Given this list of marker genes DFFB, FASLG, FAS, ACTA1, MAPK8, CASP10, MAP3K1, APAF1, FADD, HSPB1, MAPKAPK3, CYCS, DAXX, TNF, SMIM40, CASP7, CFLAR, CASP9, PAK1, MAP3K7, PAK2, MIR34C, CASP6, CASP3, ARHGDIB, FAF1, RB1, SPTAN1, PARP1, LMNA, LMNB2, MAPKAPK2, PRKDC, ACTB, ACTG1, LMNB1, IL1A, DFFA, BCL2 (NCBI Gene Id 596), JUN, CASP8 (NCBI Gene Id 841), RIPK2, MAP2K4, NFX1, here is a description of the gene set: Fas ligand pathway and stress induction of heat shock proteins Human Gene Set: WP_FAS_LIGAND_PATHWAY_AND_STRESS_INDUCTION_OF_HEAT_SHOCK_PROTEINS studied in species Homo sapiens